The following is a description of a gene set: Intracranial hemorrhage Hemorrhage occurring within the skull. Human Gene Set: HP_INTRACRANIAL_HEMORRHAGE studied in species Homo sapiens, and this is the list of marker genes: ACAD9, DNMT3A, STIM1, F13B, F8 (NCBI Gene Id 14069), CST3, CFI, MYH11, STT3A, BAP1, ERCC8, EPAS1, CD46, SDHA, MMUT, ENG, CCM2, KCNJ5, LMNA, KANSL1, F13A1, PDGFB, CYP26C1, SPARC, PCCA, MAX, MYLK, GCDH, NF1, AKT1, F7, SDHD, SMAD4, SH2B3, MAT2A, SMARCB1, PCCB, DLST, LOX, CPT2, MCFD2, ACVRL1, CACNA1D, PDCD10, TGFBR3, RET, JAK2, GALE, CYP11B2, TRAF7, FH, ESAM, DNM2, HELLPAR, ITGB3, GGCX, GP1BB, SAMD9, F5, ZMPSTE24 (NCBI Gene Id 10269), ELN, EXT2, FN1, LMAN1, VHL, THSD1, ACTA2, F2, COL3A1, NFIA, TMEM127, TGFBR1, COL4A2, ATP7A, SMARCE1, IKBKG, MFAP5, SERPINF2, CYP11B1, IVD (isovaleryl-CoA dehydrogenase), DOCK8, SMO, SNORD118, SDHAF2, THSD4, TMEM237, GDF2, SMAD2, ALPL, RNF168, GATA2, TERT, STAT2, FGG, DHPS, ADA2, USP18, ABCC6, PET100, ITGA2B, ANGPTL6, SIN3A, SDHC, FGA, KRIT1, NDE1, ERCC6 (NCBI Gene Id 282965), PRKG1, LMBRD1, CNTNAP2, SDHB, RBM10 (RNA binding motif protein 10), SUFU, HADHB, ITGA2, NOTCH3, RASA1, LMOD2, WIPF1 (NCBI Gene Id 7456), PROS1, MDH2, CLCN2, PTEN, EPOR, SMAD3, TGFBR2, FLNA (filamin A), NF2, SLC25A11, F10, KIF1B, SERPINE1, TGFB2, CFH, GP1BA, FGB, CBS, PIK3CA, PMM2, COL4A1, BICD2 (BICD cargo adaptor 2), HEY2, FOXE3, BRCC3, MMACHC, FCGR2C, IPO8, FBN1, TGFB3, GBA1, ZFX, ACTA1, CD109, DPAGT1, GAA, WAS, MARS2, GNAQ, APP